Given this list of marker genes Acadl, Hadhb, Hadha, Hadh, Echs1, here is a description of the gene set: studied in species Mus musculus Beta oxidation of lauroyl-CoA to decanoyl-CoA-CoA Mouse Gene Set: REACTOME_BETA_OXIDATION_OF_LAUROYL_COA_TO_DECANOYL_COA_COA